Given this list of marker genes Ppm1b, Tubb2b, Rnf149, Nup50, Rnf13, Gm4876, Ncam1, Col18a1 (NCBI Gene Id 12822), Pcdhgc3, Kctd7, Gpnmb, Maf, Tlr4, 1110002E22Rik, Cd276, Acbd5, 3300005D01Rik, 1110020A21Rik, Me2, Fam53b, Usp1, Aebp2, Sumf1, Sorbs2, Snd1, Echdc3, Thtpa, Hoxa11 (NCBI Gene Id 15396), Igfbp6, Nktr, Sco1, Aldh3a1, Rnft1, Mir6393, Ascc3, Arhgap22, Platr22, Smad3, Mgat1, Maff (NCBI Gene Id 17133), Podnl1, Slc37a3, Rnu11, Rnf41, Mir7238, Mrnip, Upk3bl, Thbd, Ogn, Tspan14, Birc2, Rassf5, Zc3hav1, Litaf, Cdk15, Tsen34, Arhgap12, Nckap5, Runx2os2, Gatad2a, Dclre1a, Krt80, Gfra1, Frat2 (NCBI Gene Id 212398), Scn5a, Slc7a2, Svbp, 2310081O03Rik, Lect2, Runx2 (NCBI Gene Id 12393), Tnpo1, Slco1a5, Atad2, Rab27b, Gm13293, Tex2, Gm12518, Cfl1, Fam43a, Lnpep, Pdhb, Blvra, Tcf4 (transcription factor 4), Nenf, Nelfa, Irx5, Lipt1, Slc16a14, Sbds, Rnf135, Gm11476, Fam180a (family with sequence similarity 180, member A), Depp1, Hrh1, Mir206, Dab2, Snora2b, Tyw1, Gabarapl2, Josd1, Col5a2, Amz2, Nrarp, Lifr, Mir2139, Lamc1, Il4ra, Ywhaz, Gm25939, Cp, Fryl, Otud4, Tnfsf8, Atp5mg, Sec11c, Ddx10, Zfp91, Foxred2, Dstn, Pdia4, Fbxl4 (NCBI Gene Id 269514), Stag1, Gm15722, S100a4, Trim16, Fam111a, Gm15916, Tbx3, Gtpbp2, Gm15408, Slc19a2, Gm15419, Fermt2, Nrep, Kctd10, Arb2a (ARB2 cotranscriptional regulator A), 2700068H02Rik, Zfp827, Denr, Gm28231, Tsku, Arhgap28, Dynlt1b, Disp1, Gm42788, Mir5123, Rap2a, Atosa, Kalrn, Gpx1, Lgals2, Jarid2, D830013O20Rik, Nudt18, Il33, Atg7, Nedd4, Llph, Wdr44, Dusp6, Gm13857, E2f8, Riok3, Hsd11b1, Kcnn4, Arid1a, Wdr62, Runx1, Tnfaip3, Pla1a, Serpinb6b, T2, Acta2, Mllt10, Dusp23, Gm57504, Gm11475, Tcerg1 (transcription elongation regulator 1 (CA150)), Mylk3, Grk6, Pdcl3, Synj2 (synaptojanin 2), Gm5641 (predicted gene 5641), Zc2hc1c, Acot1 (NCBI Gene Id 28195), Cald1, Tulp4, Caprin1, 1700036A12Rik, Serpinb8, Lrrc15 (leucine rich repeat containing 15), Gm26626, Enkur, Map3k8, 1110002O04Rik, Pank1, Adprm, Lrrk1, Pate1, Klf3, Plppr2, AI839979, Pkig, Csde1, Prkg2, Arl6ip5 (ADP-ribosylation factor-like 6 interacting protein 5), Scx, Stom, Tmem259, Scaf11, C130083M11Rik, Gm12415, Nmnat2, Incenp, Galntl5 (UDP-N-acetyl-alpha-D-galactosamine:polypeptide N-acetylgalactosaminyltransferase-like 5), Tgfbr2, Slc41a1, Sec61bl, Pdk1, Zfp566, Actn4, Vps11, Cks2, Rnf11, Orm3, Ctif, Mindy2, Serpine1, Tbc1d13, Zhx2, Naxd, Hoxa10, Ltbp1, Gm22847, Adamtsl4, Gm13421, Coq10b, C130026L21Rik, Gtpbp1, Camk2a, Chid1, Ppp2r5a, Tnni1, Ark2c, Arhgap24, Rapgef2 (Rap guanine nucleotide exchange factor (GEF) 2), Setd1b, Slc16a9, Gsto1, Hspb1 (heat shock protein 1), Ccny, Sulf1, Arid4a, Tmcc3 (transmembrane and coiled coil domains 3), Fbxw7, Zbtb7c, Stk40, Kcnab1, Lpar2, Adamtsl1, AI480526, Gm29083, Tle4, Pkm, Gm26885, Prelp, Map3k7cl, Adamts5, Mir7-2, Camsap2, Myc, 5031415H12Rik, Hoxc6, Bnip3l, Tmem167b, Scd1, Ehbp1, Nfkbia, Amd1, Mmp24, Dhrs3, 3110056K07Rik, B4galt5, Gm15742, Calu, Rorc, Rhobtb1, Ankrd10, Gm12496, Stam, Lrp11, H3c6, Spin4, Pakap, Ptprf, Mat2b, Cacul1, Sema3d, Sh3d19, Nf2, Cit, Pcolce2, Zfp207, Mapkapk2, Foxp1, Azin1, Capn2, Mri1, Slco2b1, Tspyl2, Tbce, Orm2, Thnsl1, Rictor, Mycbp2, Pdss1, Rnf170, Pdk4, Myh9, Vwf, Gm25897, Bach2it1, Ppm1k, Pomgnt1, Asxl2, Chrna1, Zmynd8, Gm12153, Gm28441, Vgll4, Heatr5b, Polg, Emp1, Frmd4a, Ptp4a1, Hspa8, Pmp22, Gm25541, Them4, Gm40117, Plpp3, 5930430L01Rik, 4930445N18Rik, Tgm2, Cat, Schip1, Sertad2, Mir6931, Rgs12, Wls, Usp6nl, Slc22a4, Abca8b, Zfp367, Gnas (GNAS complex locus), Rad21, Fam107b, Gm25558 (predicted gene, 25558), Hbp1, Hmgxb4, Glt8d2, Rab11fip5, Usp18 (NCBI Gene Id 68782), Mir3109, Mboat7, Tns1, Akap13, Lrig1 (NCBI Gene Id 232256), Srebf2, S100a6, Pi4k2a, Pparg, Coq3, 4930580E04Rik, Ppp1r9b, Slc26a2, Tnfrsf14, Fas, Gm13470, Rin2, Gm10010 (NCBI Gene Id 434089), Timp3, Rcan1, Popdc2, Ddx39a, Hacd4, Susd1, Gm15564, Ankrd1, Arhgap21, Slc10a6, Zfhx4, Rasgrp3 (RAS, guanyl releasing protein 3), Panx3, Svil, Aldh3b3, Fosl2, Gm16016, A230028O05Rik, Ccser2, Pgls, St6gal1, Tomm7, Ablim1, Plekhf1, Itgb5, Mrpl1, Rab5a, Id3, Stmnd1, Abtb3, Banp, Washc1, Plb1, Mturn, Mad1l1, Aldh3a2, Phldb2, Ampd3, Yipf5, Fxr2, Slc39a13, Ascl5, Bnc2, Arhgap18, Hoxa9, Lpcat3, Gm11343, Krtap1-5, Nfix, 0610012D04Rik, Alpl, Mcc, Lrrc8d, Osbpl8, Rapgef3, Gm26427, St3gal2, Rarg, Macf1, Angpt1, Il1r1, Copg1, Eci1, 1700047G03Rik, Card10, Cstf2t (cleavage stimulation factor, 3' pre-RNA subunit 2, tau), Slc25a45, Tead4, 1110002L01Rik, Tg (NCBI Gene Id 21819), Mir100hg, Bahcc1, Gm37435, Fbp2, Nabp2, Gm40038, Osbpl3, Mtmr12, Upp1, Styk1, Radil, Atf1, Impa1, Bmf (NCBI Gene Id 99362), Sh3bp4, Nepro, Lrrc61, Gm29346, Rab40c, Rbfox2, Orm1, Zfp62, Gcat, Gpr39, Lrp4, Dclk1, Gm26797, Hdgfl2, Mrps12, Gas7, Gm12707 (predicted gene 12707), Sgpp1, Lincmd1, 4930447F24Rik, Syncrip, Gga1, Spata13, Rhoq, Rad54l, Dtymk, Gm12708, Tm4sf1, Tcte2, Abhd11, Tmem218, Gm14137, Gstm7, Ogdh, Blcap, here is a description of the gene set: from publication Yevshin I, Sharipov R, Kolmykov S, Kondrakhin Y, Kolpakov F (PMID 30445619) studied in species Mus musculus Mouse Gene Set: MSX1_TARGET_GENES Genes containing one or more binding sites for (Msx1) in their promoter regions (TSS -1000,+100 bp) as identified by GTRD version 20.06 ChIP-seq harmonization.